The following is a description of a gene set: studied in species Homo sapiens Human Gene Set: HP_DECREASED_CIRCULATING_COMPLEMENT_C3_CONCENTRATION Decreased circulating complement C3 concentration Concentration of the complement component C3 in the blood circulation below the lower limit of normal., and this is the list of marker genes: TREX1, PXK, IRF5, ETS1, IL10, CFH, PRKCD, CR2, THBD, CFHR3, BLK, PTPN22, PLCG1, UBE2L3, CFI, ITGAM, DNASE1, CD46, TNIP1, C3, LMNB2, TNFSF4, SPP1, DNASE1L3, IGHG1, JAZF1, C4B, PDCD1, C4A, SAT1, STAT4 (NCBI Gene Id 6775), CTLA4, FCGR3B, HLA-DRB1, PACS1, FCGR2B, MECP2, TNFAIP3, IRAK1, CFHR1, TLR7, BANK1, KIAA0319L